The following is a description of a gene set: Human Gene Set: chr2q11 studied in species Homo sapiens, and this is the list of marker genes: CNNM4, EIF5B, LINC01870, GPAT2P2, UBTFL6, NPAS2-AS1, ENSG00000291024, LINC01868, UBTFL5, LYG2, CNN2P11, UNC50, CYP4F32P, MAP4K4, CRACDL, RNF149, LYG1, GXYLT1P7, ADRA2B (NCBI Gene Id 151), ZNF2, TXNDC9, RPL31, RPS6P3, RN7SL313P (NCBI Gene Id 106481008), ZAP70, MGAT4A, MITD1, ASTL, CREG2, IGKV2OR2-1, MRPL30, PDCL3, IL1R1, FABP7P2, MIR3127, BBIP1P1, ENSG00000290941, ZNF514, C2orf15, RN7SL575P, RNU4-84P, COA5 (cytochrome c oxidase assembly factor 5), SNORD89, CYCSP7 (NCBI Gene Id 164837), CNOT11, FER1L5, ENSG00000307316, VWA3B, ITPRIPL1, RPS24P6, PRCPP1, FAHD2A, KCNIP3, NMS, SNX18P14, ANKRD20A8P, RFX8, IGKV2OR2-10, LINC01127, ANKRD36C, IGKV2OR2-7, TEKT4, GPAT2, TRIM64FP, REV1, OR7E102P, PROM2, RNU6-1320P, IGKV2OR2-8, INPP4A, LINC03052, HMGN2P22, SOWAHCP5, LINC01104, FAM178B, YWHAQP5, APPAT, NPAS2, ENSG00000301580, TRIM43B, ANKRD36 (NCBI Gene Id 375248), AQP7B, LINC00342, SMC3P1, SEMA4C, TSGA10, NCAPH, MAL, ANKRD39, TMEM131, STARD7-AS1, UBTFL3, MIR5696, IGKV1OR2-3, ZNF892, RN7SL210P, TRIM43, COX5B, ARID5A, CNNM3-DT, LMAN2L, NEURL3, SNRNP200, CNNM3, SLC2AXP1, CIAO1, RNU7-96P, FAM95A, LINC01849, NANOGNBP1, IGKV3OR2-5, ENSG00000286737, LONRF2, LIPT1, TBC1D8-AS1, HMGN1P36, IGKV2OR2-2, C2orf92 (chromosome 2 open reading frame 92), ANKRD23, FAHD2CP, IGKV1OR2-11 (NCBI Gene Id 28863), RNU7-46P, IGKV1OR2-6, CNN2P8, BMS1P23, GPAT2P1, IGKV1OR2-9, ENSG00000286101, CHST10, MTCO1P48, AFF3, ATP5F1BP1, KANSL3, STARD7, ENSG00000235480, IL1R2, ANKRD36B (NCBI Gene Id 80265), ANKRD33BP1, ENSG00000303465, IGKV2OR2-7D, CNGA3, TRIM43CP, LINC02611, MAL-AS1, FAHD2B, TRIM51JP, ENSG00000298685, DUSP2 (NCBI Gene Id 1844), ACTR1B, RNU4-8P, ARPP19P2, RNA5SP101, RALBP1P2 (NCBI Gene Id 648466), TBC1D8, TMEM127 (transmembrane protein 127), MTCO3P45, MRPS5